The following is a description of a gene set: Mouse Gene Set: REACTOME_REGULATION_OF_PTEN_STABILITY_AND_ACTIVITY studied in species Mus musculus Regulation of PTEN stability and activity, and this is the list of marker genes: Psmc6, Adrm1, Psmd1, Psma7, Psmb6, Csnk2b, Prex2, Ubc, Psma4, Uba52rt, Ubb, Psmb5, Psmd6, Trim27, Psmd2, Csnk2a1, Psma2, Psma5, Psma3, Psma6, Psmd7, Uba52, Otud3, Psmc2, Psmc3, Psmb1, Rps27a, Psmd8, Stub1, Xiap, Psmd13, Nedd4, Psmb2, Rnf146, Psmb4, Tnks2 (tankyrase, TRF1-interacting ankyrin-related ADP-ribose polymerase 2), Wwp2, Psmb3, Psmc5, Akt2, Pten, Psma1, Mkrn1, Csnk2a2, Psmc4, Akt1, Psmd12, Frk, Usp13, Psmd14, Psmd11, Tnks, Psmd3, Psmc1, Akt3, Psmb7